The following is a description of a gene set: part of: Glycogen storage diseases Glycogen storage disease type II (GSD II - Pompe's disease) is caused by mutations that reduce or eliminate the activity of lysosomal alpha-glucosidase (GAA). The presentation of GSD II varies with the severity of the mutation: patients with little or no GAA activity are affected shortly after birth and multiple tissues are severely affected. Patients with higher levels of GAA activity present later in life, often with symptoms restricted tocardiac and skeletal muscle (Leslie & Tinkle). At a cellular level, symptoms of the disease are due to accumulation of structurally normal glycogen in lysosomes. Glycogen, thought to enter lysosomes via autophagy, is fully degraded by GAA, but accumulates if the enzyme is absent or reduced in activity.<p>The two mutant alleles annotated here are associated with near-complete loss of enzyme activity and early onset of disease. Many other mutant alleles have been described and their residual activities correlated with disease presentation (e.g., Kroos et al. 2012). species: Homo sapiens Reactome Pathway: Glycogen storage disease type II (GAA), and this is the list of marker genes: GYG1, GAA